Given this list of marker genes VPS50, LRRD1, ANKIB1, PPP1R9A, DYNC1I1, COL1A2, CALCR, OCM2, CYP3A7, CYP3A5, ZSCAN25, ZNF789, FAM200A, CPSF4, GNGT1, ZNF655, BHLHA15, PDAP1, TRRAP, SDHAF3, PEX1, CFAP69, RBM48, BAIAP2L1, SLC25A13, PON1, ZNF394, PTCD1, CYP51A1, NPTX2, PON3 (NCBI Gene Id 94886), ATP5MF, FAM133B, SAMD9L, BRI3, PON2, ZKSCAN1, FZD1, CDK14, AZGP1, ASB4, ARPC1A, GJC3, TRIM4, CASD1, GNG11, PDK4, AKAP9, MTERF1, TMEM130, TECPR1, GTPBP10, GATAD1, DLX5, SEM1, BET1, SMURF1, BUD31, LMTK2 (lemur tyrosine kinase 2), OR2AE1, ASNS, ARPC1B, CYP3A4, ZKSCAN5, PEG10, KRIT1, HEPACAM2, SAMD9, CDK6, TAC1, CYP3A43, DLX6, SGCE, TFPI2, CLDN12 (NCBI Gene Id 9069), here is a description of the gene set: studied in species Homo sapiens Human Gene Set: NIKOLSKY_BREAST_CANCER_7Q21_Q22_AMPLICON A single cancer cell contains large numbers of genetic alterations that in combination create the malignant phenotype. However, whether amplified and mutated genes form functional and physical interaction networks that could explain the selection for cells with combined alterations is unknown. To investigate this issue, we characterized copy number alterations in 191 breast tumors using dense single nucleotide polymorphism arrays and identified genes with copy number gain organized into 30 amplicons. Amplicons were distributed unequally throughout the genome. Each amplicon had distinct enrichment pattern in pathways, networks, and molecular functions, but genes within individual amplicons did not form coherent functional units. Genes in amplicons included all major tumorigenic pathways and were highly enriched in breast cancer-causative genes. In contrast, genes with somatic mutations in breast cancer were distributed randomly over the genome, did not represent a functionally cohesive gene set, and were relatively less enriched in breast cancer marker genes. Mutated and gained genes did not show statistically significant overlap but were highly synergistic in populating key tumorigenic pathways including transforming growth factor beta, WNT, fibroblast growth factor, and PIP3 signaling. In general, mutated genes were more frequently upstream of gained genes in transcription regulation signaling than vice versa, suggesting that mutated genes are mainly regulators, whereas gained genes are mostly regulated. ESR1 was the major transcription factor regulating amplified but not mutated genes. Our results support the hypothesis that multiple genetic events, including copy number gains and somatic mutations, are necessary for establishing the malignant cell phenotype. from publication Nikolsky Y, Sviridov E, Yao J, Dosymbekov D, Ustyansky V, Kaznacheev V, Dezso Z, Mulvey L, Macconaill LE, Winckler W, Serebryiskaya T, Nikolskaya T, Polyak K (PMID 19010930) Genes within amplicon 7q21-q22 identified in a copy number alterations study of 191 breast tumor samples.